The following is a description of a gene set: The process in which a relatively unspecialized cell acquires specialized features of a vascular smooth muscle cell. Mouse Gene Set: GOBP_VASCULAR_ASSOCIATED_SMOOTH_MUSCLE_CELL_DIFFERENTIATION species: Mus musculus, and this is the list of marker genes: Mir145a, Nfatc2, C3, Mir143, Comp, Sod2, Cfh, Hey2, Srf, Gata6, Mrtfb, Smad6, Qki, Notch1, Prok2, Pdgfrb, Pdgfb, Mesp1, Nfatc4, Sgcb, Cfd, Pitx2, Nfatc3, Adm, Epc1, Fgf9, Ramp2, Dnmt1 (DNA methyltransferase 1), Myocd, Ednra, Pdcd4, Smarca2, Hes1, Pbrm1, Vegfa, Kit, Vangl2, Gper1, Ctnnb1, Cth, Aplnr, Efemp2, Smarca4, Eng, Nfatc1